Given this list of marker genes CDKN1A, GPNMB, BTG3, PMP22, CXCL1, IL6, FGFBP1, ADRA1A, BTG1, BTG2, CDKN2A, IL1B, S100A11, KLF10, IL1A, NME2, IGFBP6, EIF2AK2, SSTR3, RARRES1, KAT2B, AIF1 (NCBI Gene Id 9471), EMP3, TM4SF4, IFITM1, GAS1, CXCL8, NME1, CDKN2B, here is a description of the gene set: Growth inhibitory genes. Human Gene Set: MODULE_488 studied in species Homo sapiens